Given this list of marker genes Runx1, Tnfsf8, Runx3, Eomes, Nckap1l, Otud5, Satb1, Gpr18, Tox, Cbfb, Gimap1, Lilrb4b, Lilrb4a, Ifng, Psmb11, Pax1, Irf1, Igtp, Slc4a2, Zbtb7b, Socs1, Bcl2, here is a description of the gene set: The process in which a relatively unspecialized T cell acquires specialized features of a mature CD8-positive, alpha-beta T cell. Mouse Gene Set: GOBP_CD8_POSITIVE_ALPHA_BETA_T_CELL_DIFFERENTIATION studied in species Mus musculus